Given this list of marker genes HPS1, CLDN10, MLPH, RARB, DRD2, DTX2P1-UPK3BP1-PMS2P11, LYST, FMO4, CD53, WNT6, STXBP6, LY6G5C, NTS, PPP1R14D, MMP9, LGALS14, LPAR6, DMWD, KIF5A (kinesin family member 5A), SLAMF1, ENGASE, SLC22A14, TTK, RAD51D, P2RY4, ZNF419, BRCA1, CTXND1, RANBP2, NIPSNAP3B, TCTA, REG3A (NCBI Gene Id 5068), MPP3, N4BP1, GPX3, TRAPPC13, MAP2K5 (mitogen-activated protein kinase kinase 5), TP53TG3, MYL4, ADAM21, NEK1, CYP1A2 (NCBI Gene Id 1544), TP63, TBXA2R, PPP3CC, CIDEC, RFPL3, FCER1G, GNPTAB, GGT1, WBP4, ZNF576, CYP2C9, MCC, SLC5A5, NFAT5, CYLC1, ACRV1, ITK, A1CF, PDGFD, SIKE1, CD80, FXYD3, DLEU2, FMOD, CASP1, PRDX3 (NCBI Gene Id 29017), PGLYRP4, SIGLEC1, CYP2A6, KCNMB4, ATP6V1D, PSG1, CDH10, RPL38, GSTA1, CYLC2, UBE2D4, PSG4, MTAP, PRRX1, FAXDC2 (NCBI Gene Id 91674), GRM6, KLRG1, ATN1, PIK3R5, ADAMTS9, ABCA1, here is a description of the gene set: species: Homo sapiens The cytokine scatter factor (SF) (hepatocyte growth factor) transduces various biologic actions, including cell motility, invasion, angiogenesis and apoptosis inhibition. The latter is relevant to understanding the role of SF in promoting tumor cell survival in different contexts, for example, detachment from basement membrane, growth in metastatic sites and responses to chemo- and radiotherapy. Previously, we showed that SF protects cells against apoptosis owing to DNA damage, by a mechanism involving phosphoinositol-3-kinase/c-Akt signaling. Here, we used DNA microarray assays to identify c-Akt-regulated genes that might contribute to cell protection. DU-145 human prostate cancer cells were transfected+/-a dominant-negative mutant Akt, treated+/-SF and analysed for gene expression using Affymetrix arrays. These studies identified SF-regulated genes for which induction was c-Akt-dependent vs -independent. Selected microarray findings were confirmed by semiquantitative and quantitative reverse transcription-polymerase chain reaction. We tested the contribution of four SF-inducible/c-Akt-dependent genes (AMPD3, EPHB2, MX1 and WNT4) to protection against adriamycin (a DNA topoisomerase IIalpha inhibitor) using RNA interference. Knockdown of each gene except EPHB2 caused a small but significant reduction in the SF cell protection. The lack of effect of EPHB2 knockdown may be due to the fact that DU-145 cells contain a single-mutant EPHB2 allele. A combination of three small interfering RNAs blocked most of the protection by SF in both DU-145 and T47D cells. These findings identify novel c-Akt-regulated genes, some of which contribute to SF-mediated cytoprotection. Genes down-regulated in DU-145 cells (prostate cancer) in the presence but not in the absence of a dominant negative form of AKT1 upon exposure to HGF for 48 h. from publication Xu J, Gao M, Fan S, Meng Q, Goldberg ID, Abounader R, Ressom H, Laterra JJ, Rosen EM (PMID 17099727) Human Gene Set: XU_HGF_TARGETS_REPRESSED_BY_AKT1_DN